The following is a description of a gene set: part of: Plasma lipoprotein clearance species: Mus musculus electronically inferred by orthology from the curated human pathway This event has been computationally inferred from an event that has been demonstrated in another species.<p>The inference is based on the homology mapping from PANTHER. Briefly, reactions for which all involved PhysicalEntities (in input, output and catalyst) have a mapped orthologue/paralogue (for complexes at least 75% of components must have a mapping) are inferred to the other species. Reactome Pathway: Chylomicron clearance, and this is the list of marker genes: Lipc, Apob, Ldlr, Apoe